Given this list of marker genes MAF, ACKR3, PDZRN4, BRINP2, SST, LHX6, RBP1, here is a description of the gene set: species: Homo sapiens from publication Fan X, Dong J, Zhong S, Wei Y, Wu Q, Yan L, Yong J, Sun L, Wang X, Zhao Y, Wang W, Yan J, Wang X, Qiao J, Tang F (PMID 29867213) Human Gene Set: FAN_EMBRYONIC_CTX_IN_2_INTERNEURON